Given this list of marker genes Dusp10, Hfe, Slc22a13, Atad5, Tnfsf13b, Sash3 (SAM and SH3 domain containing 3), Card9, Zp3, Shld3, Hmgb1, Cd160, Nlrp3, H2-M10.2, Il33, Fadd, Lgals1, H2-M3, Msh2, Clec4g, Cd24a, Lgals9 (lectin, galactose binding, soluble 9), H2-M2, Pla2g4a, Ccl20, Cr2, Tnfsf13, Il20rb, H2-Q4, Cd55b, Aplf, Ufl1, Vsir, Alox15, Ighg1, Irf7, Pycard, Tnfsf4, Kmt5b, Slc11a1, Ndfip1, H2-T13, Mir301, Lta, Nlrp10, Cd69 (CD69 antigen), Slc15a4, Mir181b-2, Nectin2, H2-Q7 (NCBI Gene Id 15018), Il4, Il23a, Havcr2, H2-M1, P2rx7, Tyk2, Ywhag, Cd74, Pms2, H2-T23, Supt6, Paxip1, Prkcq, Map3k7, Ephb2, Tnfrsf1b, Foxp3, Cd40, Cd46, Xcl1, B2m, Cd226, H2-M10.3, H2-D1, Kmt5c, Fcer1a, Il1b, H2-Q6, Azgp1, Il4i1, Slamf1, Mr1, Il2, H2-M10.1, Pdcd1, Shld2, Jak3, Loxl3, Trim27, Pvr, Anxa1, Lilrb4b, Tfrc, Eif2ak4, H2-M10.5, Cd1d2, Il27, Brd2, Exosc6, Ripk3, Il23r, Rc3h2, Zp3r, Il7r, Cd44, Foxj1, Malt1, Trpm4, Cd274, Hspd1, Ep300, Irf1, Klrd1, H2-M10.4, Ahr, 6030468B19Rik, Cd81, Dennd1b, Nfkbiz, Hmces (NCBI Gene Id 97315), C3, Brd4, Fcer1g, Ascl2, Pf4, Il27ra, Zbtb7b, Fzd5, Susd4, Rc3h1, Cd1d1, Tnf, Tnfsf18, Exosc3, Fcgr1, H2-T22, Cr1l, Zbtb1, Pkn1, Il12b, Clec7a, Shld1, Ppp3cb, Hspa8, Klhl22, Zc3h12a, Il4ra, Nfkbid, Rsad2, Parp3, Mir326, Prkaa1, Samsn1, Clcf1, Ada, Raet1e, H2-T24, Ccr6, Cd28, Jak2, Mef2c (NCBI Gene Id 71350), Spn, H2-M5, Ccr2, Ccl19, Dusp22, Ulbp1, H2-M9, Hlx, Mif, H60b, Gimap3, H2-Q1, Gata3, Hpx, H2-Q2, Traf6, Raet1d, Tnfrsf13c, Ptpn6, Otud5, Ifnb1, BC037156, Mir181b-1, H60c, Cyrib, H2-T3 (histocompatibility 2, T region locus 3), Socs5, H2-T15, H2-T5, Gimap5, Was, Ripk2, Fbxo38, Il1rl1, Mad2l2, H2-DMa, Trp53bp1, Fcgr3, Bcl6, Il1r1, Skap1, Opa1, Tnfrsf14, Il18, Lilrb4a, Ighg2b, Ifng, Fcer2a, Ceacam1, Ptprc, Arid5a, H2-M10.6, Trem2, Fcgr2b, Nod2, Mlh1, H2-K1, H2-M11, Il18r1, Tgfb1, 2410137M14Rik, C4bp, Nckap1l, Il6, H2-Ea, Btk, Cd4, Clec4n, H2-Q10, Il12a, Akirin2, Prkcz, Muc4, Pagr1a, Smad7, Pnp, Tbx21, Sirt1, Rif1, Tap2, Cd55, Stat6, Tnfaip3, Stx7, Adcy7, Ager, Nsd2, Il12rb1, Dpp4 (dipeptidylpeptidase 4), Cd80, Fut7, Arg1, Ccr7, Traf2, here is a description of the gene set: Mouse Gene Set: GOBP_REGULATION_OF_ADAPTIVE_IMMUNE_RESPONSE Any process that modulates the frequency, rate, or extent of an adaptive immune response. species: Mus musculus